Given this list of marker genes CBX1, UNG, KPNA2, RPL35, CCNO, NPM1, H2BC13, H2AZ1, MSH2, NCL, RAD51, XPO1, H2AX, TCOF1, NOLC1, H2BC12, RAD51C, SMARCC1, here is a description of the gene set: rRNA processing and DNA repair. Human Gene Set: MODULE_392 species: Homo sapiens